Given this list of marker genes MKKS, PDX1, NEUROD1, BBS1, BBS10, LMNA, BBS2, CEP19, ZMPSTE24, ALMS1, SCAPER, BBS4, BBS7, PTF1A, SCN4A, KCNJ18, GYS2, KCNE3 (NCBI Gene Id 10008), IFT74, BMP6, KLF11, IFT172, DYRK1B, PRORP, CACNA1S, HNF4A, ARL6, BBIP1, CFAP418, INSR, TFG, SCLT1, GLI3, ARMC5, KCNJ11, GCK, ZFP57, WRN, GCSH, ADRA2A, CYC1, SLC5A2 (solute carrier family 5 member 2), GABRA3, SLC2A2, NPHP1, APPL1, BLK, KHK, ENPP1, HNF1A, BCS1L, HYMAI, STAT3, CEP290, SH2B1, RIMS2, BBS12, AFF4, WDPCP, PPARG, RFX6, TRIM32, INS, PCYT1A, PAX4, PIK3R1, LRPPRC, GATA6, LZTFL1, SDCCAG8, ABCC8, PTPN22, NARS2, IFT27, BBS9, ITPR3, CEL, PLAGL1 (PLAG1 like zinc finger 1), HFE, BBS5, TTC8, ACAT1, IL6, PLAAT3, SHPK (sedoheptulokinase), MKS1, here is a description of the gene set: Human Gene Set: HP_HYPERGLYCEMIA An increased concentration of glucose in the blood. Hyperglycemia species: Homo sapiens